The following is a description of a gene set: from publication Cui A, Huang T, Li S, Ma A, Pérez JL, Sander C, Keskin DB, Wu CJ, Fraenkel E, Hacohen N (PMID 38057668) Cytokines mediate cell-cell communication in the immune system and represent important therapeutic targets. A myriad of studies have highlighted their central role in immune function, yet we lack a global view of the cellular responses of each immune cell type to each cytokine. To address this gap, the authors created the Immune Dictionary, a compendium of single-cell transcriptomic profiles of more than 17 immune cell types in response to each of 86 cytokines (>1,400 cytokine-cell type combinations) in mouse lymph nodes in vivo. A cytokine-centric view of the dictionary revealed that most cytokines induce highly cell-type-specific responses. For example, the inflammatory cytokine interleukin-1β induces distinct gene programmes in almost every cell type. A cell-type-centric view of the dictionary identified more than 66 cytokine-driven cellular polarization states across immune cell types, including previously uncharacterized states such as an interleukin-18-induced polyfunctional natural killer cell state. species: Mus musculus Mouse Gene Set: CUI_T_CELL_CD4_IFNE_RESPONSE_UP Genes positively differentially expressed in cell type: CD4+ T cell upon treatment with cytokine: IFN-ε in mouse lymph nodes in vivo., and this is the list of marker genes: Parp14, Ms4a4b, Ly6a, Ifit1, Isg15, Ifit3, Ifi27l2a, Ifi206, Ifi214, Irf7, Slfn1, Ifi203, Samd9l, Bst2, Slfn5, Rtp4, Rnf213, Usp18